Given this list of marker genes TUSC2, MIR181C, MIR135A1, NCKAP1L, FOXP3, LY9, TLR4, CARD9, IL23R, SPHK1, DDIT3, IL12A, ARG2, ARID5A, MIR26A1, IL6, ZBTB7B, IFNG, SLAMF6, OPA1, IL36RN, TNFSF4, MIR20A, PRKCQ (protein kinase C theta), IL23A, JAK2, VSIR, PHB1, RFTN1, OSM, IL2, SLC7A5, MIR383, NOD2, TGFB1, IL27RA, MYD88, IL18, MIR136, CCL1, MIRLET7F1, PRNP, IL15, NR1H4, TYK2, MIR146B, BTK, IL12B, IL21, here is a description of the gene set: studied in species Homo sapiens The appearance of any member of the interleukin-17 family of cytokines due to biosynthesis or secretion following a cellular stimulus, resulting in an increase in its intracellular or extracellular levels. Human Gene Set: GOBP_INTERLEUKIN_17_PRODUCTION